The following is a description of a gene set: species: Homo sapiens Human Gene Set: GOBP_NEGATIVE_REGULATION_OF_OSTEOCLAST_DEVELOPMENT Any process that stops, prevents or reduces the frequency, rate or extent of osteoclast development., and this is the list of marker genes: FBXW7, FBN1, LILRB1, CLDN18, LTF